The following is a description of a gene set: Any process that activates or increases the frequency, rate or extent of complement activation. Human Gene Set: GOBP_POSITIVE_REGULATION_OF_COMPLEMENT_ACTIVATION studied in species Homo sapiens, and this is the list of marker genes: CR1, TREM2 (triggering receptor expressed on myeloid cells 2), MIR520B, PHB1, MIR520E, IL1B, C3